Given this list of marker genes CYP27B1, here is a description of the gene set: Vitamin D3 (cholecalciferol), synthesised in human skin by ultraviolet radiation action on 7-dehydrocholesterol, does not possess any biological activity. Vitamin D hormonal activity requires hydroxylation at the 25 and 1-alpha positions by cytochrome P450 enzymes CYP2R1 and CYP27B1 respectively. Vitamin D 25-hydroxylase (CYP2R1) catalyses the hydroxylation of vitamin D3 to calcidiol (CDL). Subsequent 1-alpha-hydroxylation of CDL by CYP27B1 produces calcitriol (CTL). CTL binds and activates the nuclear vitamin D receptor, with subsequent regulation of physiologic events such as calcium homeostasis, cellular differentiation and proliferation.<br><br>Defects in CYP27B1 can cause rickets, vitamin D-dependent 1A (VDDR1A; MIM:264700), a disorder caused by deficiency of the active form of vitamin D (CTL) resulting in defective bone mineralization and clinical features of rickets. To date, 47 mutations have been identified, the majority of them (28) being missense mutations. part of: Metabolic disorders of biological oxidation enzymes Reactome Pathway: Defective CYP27B1 causes VDDR1A studied in species Homo sapiens